The following is a description of a gene set: A spindle that forms as part of meiosis. Several proteins, such as budding yeast Spo21p, fission yeast Spo2 and Spo13, and C. elegans mei-1, localize specifically to the meiotic spindle and are absent from the mitotic spindle. studied in species Mus musculus Mouse Gene Set: GOCC_MEIOTIC_SPINDLE, and this is the list of marker genes: Kash5, Ska3, Bora, Gsk3b, Aspm, Rsph1, Aurkc, Cpeb1, Septin1, Shcbp1l, Sirt2, Mapk15, Aurka, Cntrl, Hspa2, Ska1, Fbxo5, Pnma5, Ska2, Rps6ka2, Incenp